Given this list of marker genes Nanp, Cmah, Slc35a1, Gne, Cmas, Nans, here is a description of the gene set: The chemical reactions and pathways involving CMP-N-acetylneuraminate, a substance composed of 5-(acetylamino)-3,5-dideoxy-D-glycero-D-galacto-non-3-ulosonic acid in glycosidic linkage with cytidine monophosphate. Mouse Gene Set: GOBP_CMP_N_ACETYLNEURAMINATE_METABOLIC_PROCESS studied in species Mus musculus